Given this list of marker genes TRAPPC2, KDM8, ATOX1, NUDT18 (NCBI Gene Id 79873), DAPP1, UBA3, TNFRSF10C, BSG, APP, IL16, UBL5, DHRS7B, FBP1, ZNF778, SNX3, FLAD1, DIS3, CEP164, SLC35C2, PRKDC, SLC27A6, ZFP36L2, MRFAP1L1, CALCOCO1, NUP133, FZD3, LIG3, AMPD3, SPCS3, EXT2, SLC26A4, PTPA, MACIR, VSNL1, HPF1, PRKAA2, KCNE2, ABITRAM, USP4, F5, SMR3B, SNAPC5, TST, DBI (NCBI Gene Id 1622), NDUFAF4, STK26, RYK, TALDO1, KDELR1, SLC33A1, MOB3B, ZEB1, SNRNP40 (small nuclear ribonucleoprotein U5 subunit 40), PCDH17, TMEM80 (transmembrane protein 80), ANKRD46, DBP, PICALM, ZNF592, SRI, GPATCH2L, TMEM223, MTERF4, KIF15, NHLRC2, H4C8, GPRC5C, ARL6IP4, ARHGAP33, PGM5, SERPINB8, SEMA6D, FXYD1, IFIT3, ANKRD40, VDR, CHPT1, ABHD10, PSME3IP1 (NCBI Gene Id 80011), MYO1F, TMF1 (NCBI Gene Id 7110), IKBKE, CLEC4A, GAGE1, EPS15L1, ASXL2 (NCBI Gene Id 55252), CNKSR2, ZFR, ZNF516, ACTA2, RECQL, RGS19, PFDN2, PRDX6, PALMD, NLRX1, NAT1, LEPROTL1, TWF2 (NCBI Gene Id 11344), S1PR4, TMEM186, SIRPA, NAGK, ADGRE1, BMP2K, CENPF, CD1D, CDC14B, TMEM19, GNS, TFPT, SNRPD3 (NCBI Gene Id 6634), RAB14, TSNAX, FMR1, TSN, TSR3, GFI1B, MIA3, SNX5, TMEM30A, SNRNP27, IL17RA, CRLF3, PLA2G4A, MAN1A1, ELAC2, STYXL1, H2BC14, TIMP3, ANKH, KL, MRPL41, MT1HL1, ZNF174, RSBN1, MYT1L, SCG2, ILKAP, ZBTB6, ECHDC3, COX4I1, TMCC2, RALBP1, TNIP1, XAF1, PLEKHA5, ELOB, GPKOW, IGHMBP2, LRIT1, PRRC2B, HMGB2, VAMP3, ENPP3, MKKS, BCAS3, CLCN3, TRIOBP, MT1H, ATG101, PBX3, RCOR1, NCOA4, TASOR, LMAN2L, SKA1, POLR1B, UBE2K, DCP2, TMEM248, ZBTB18, TMEM140, CYFIP1, UBE2L3, NCOA2, COPB2, PRCP, H4C9, NR2F6, VAV1, SLC26A6, PSMD3, RNF41, POLB, DRC3, CEP162, LIMS1, NUP62CL (NCBI Gene Id 54830), CEP55 (centrosomal protein 55), RNF5, KCNJ2, MZT2A, ANKRD26, PAPSS1, CLCN4, CILK1, here is a description of the gene set: Human Gene Set: GSE3982_CTRL_VS_PMA_STIM_EOSINOPHIL_UP In the present study we used Affymetrix oligonucleotide microarrays to produce gene transcription profiles for the major leukocyte types in humans. This comprehensive dataset enabled us to not only establish which genes were expressed in each leukocyte type, but also which genes were expressed in each subset after activation. The used of a comprehensive dataset of gene profiles from all the major human leukocyte subsets enabled a novel and powerful means for identification of genes associated with single leukocyte subsets, or different immune paradigms. from publication Jeffrey KL, Brummer T, Rolph MS, Liu SM, Callejas NA, Grumont RJ, Gillieron C, Mackay F, Grey S, Camps M, Rommel C, Gerondakis SD, Mackay CR (PMID 16474395) Genes up-regulated in comparison of untreated eosinophils versus eosinophils treated with PMA at 2 h. species: Homo sapiens